The following is a description of a gene set: Human Gene Set: HP_ABNORMAL_AUTONOMIC_NERVOUS_SYSTEM_PHYSIOLOGY A functional abnormality of the autonomic nervous system. studied in species Homo sapiens Abnormal autonomic nervous system physiology, and this is the list of marker genes: MAPT, ATXN8OS, ATP1A2, B2M, VPS13C, ALK, KCNE2, PRKN, GIGYF2, ATP7A, DBH, ATXN3, COL1A1, AAAS, LEPR, TNFSF15, RFC1, TBX5, PARK7, EIF4G1, PPOX, NOS1AP, IRF5, CALM1, CAV3, GBE1, CHRNA3, SCN3A, TTR, NR4A2, SPG11, LEP, COL5A2, IL12A, KCNE1, CACNA1C, SCN5A, MECP2, SLC1A3, HTRA2, CALM3, RELN, NTRK1, GLA, ACBD6, CACNA1A, MYCN, TNPO3, TBP, GABBR2, KCNQ1, DNAJC6, SNTA1, ECE1 (endothelin converting enzyme 1), TSPYL1, GNB2, SIM1, WFS1, VPS11, POU2AF1, CHCHD2, SAA1, SOX10, CRELD1 (cysteine rich with EGF like domains 1), LMO1, LMNB1, CISD2, HACE1, MMEL1 (membrane metalloendopeptidase like 1), PRNP, ATXN2, VPS35, IL12RB1, ARSA, BRAT1, SPIB, SCN10A, CALM2, KCNH2, GBA1, SNCAIP, POLR3A (NCBI Gene Id 11128), GFAP, SCN11A, MT-TT, FBXO7, SLC6A2, CYP11B2, LIN28B, RET, VPS13A, PHOX2B, CYB561, FMR1, DNAJC13, LIFR, ASCL1, TRDN, PINK1, KCNJ5, KIF1B, COQ2, SCN9A, ACOX1, PLA2G6, CCT5, TUBB3, ELP1, ATP1A3, ERBB3, UCHL1, DEPDC5, GMPPA, SNCA, WDR45, SCN4B, GSN, SYNJ1, ANK2, PSAP, PODXL, LRRK2, ADH1C, LGI1, CAV1, COL5A1, SYNE1, TXN2, AKAP9, SLC18A2, HEXB